Given this list of marker genes Rgs11, Ihh, 6430548M08Rik, Pomk, Cdk17, Synpo2l, Amer2, Dpysl5, Mtss2, Nav1, Map2k7, Wnt1, Rps6ka1, Setbp1, C5ar1, Tat, Ift46, Afap1, Snhg11, Fgd1, Stk32b, Lbh, Card10, Klf8, Ar, Pea15a, Krtap5-4, Mansc1, Hip1, Dtx4, Ark2c, Fbxw8, Ppp1r1c, Mllt1, Pitpnb, Pxk, Elf5, C1ql2, Dpysl3, Gcn1, Sec14l1, Mpp2, Ctdsp1, Cpa4, Man1a, Nxf1, Rinl, G6pdx, Glg1, Dlgap4, Nol4l, Trim67, Rgs8, Ahcyl2, Strc, Lasp1, Plxna4, Fndc3a, Parvb, Phospho1, Arf3, Yeats4, Olr1, Arcn1, Kank2, Srrm4, Rdh16, Lrrc8d, Zfp346, Camk1, Gdpd4, Arrdc1 (NCBI Gene Id 99134), Man1b1, Srf, Dscaml1, Hoxc4, Sec22c, Mrgpre, Lingo1, Evi2b, Ttc39d, Prom2, Srgap3, Sbk3, Pum1, Kirrel1, Pkp2, Mylk4, Mgat4c, Kmt2a, Tgm2, Pef1, Katnbl1, Slc35d1 (NCBI Gene Id 242585), B4galt3, Igsf9b, Susd6, Siglecl2, Ciapin1, Gmfb, Diras1, Tbc1d5, Itsn1, Nhsl3, Gca, Abcg4, Nhsl2, Baz2a, Wasf2 (NCBI Gene Id 52063), Slc44a5, Atp6v0c, Lrrc71, E2f2, Zfp710, Ric8a, Nuggc, Runx1t1, Gnal, Cplx1, Nras, Cyp17a1, Tifab, St6galnac3, Ipcef1, Arsk, Minar2 (NCBI Gene Id 225583), Rab6a, Svopl, Mbd4, Mlph, Mtcl2, Chst14, Tnfsf8, Lilrb4a, Trp63, Slc12a7, Jph4, Ilrun, Tkfc, Thrb, Klk4, Col4a4, Gal3st3, Slc8a1, Cbl, Nkain2, Pgm3, Odad1, Myoz3, Foxj2, U2af2, Lin7a, Ywhaz, Bsn, Gdap1l1, Sema4g, Exph5, Nkx2-1, Ncln, Fam76a, Slc24a3, Gpatch8, Prg4, Vapb, Bcl11b, Ccbe1, Eppk1, Ccser2, Nlrp3, Psmd11, Brpf3, Zfyve28, Tulp4, Map3k9, Taok1, Braf, Il2ra, Sypl2, Twist2, Atp7a, Khdrbs2 (NCBI Gene Id 170771), Dmrta1, here is a description of the gene set: Mouse Gene Set: MIR_5110 from publication Chen Y, Wang X (PMID 31504780) Genes predicted to be targets of miRBase v22 microRNA mmu_miR_5110 in miRDB v6.0 with MirTarget v4 prediction scores > 80 (high confidence targets). species: Mus musculus